The following is a description of a gene set: from publication Barrier A, Lemoine A, Boelle PY, Tse C, Brault D, Chiappini F, Breittschneider J, Lacaine F, Houry S, Huguier M, Van der Laan MJ, Speed T, Debuire B, Flahault A, Dudoit S (PMID 16091735) Human Gene Set: BARRIER_CANCER_RELAPSE_NORMAL_SAMPLE_DN studied in species Homo sapiens Down-regulated genes in non-neoplastic mucosa samples from colon cancer patients who developed recurrence of the disease. This study assessed the possibility to build a prognosis predictor, based on microarray gene expression measures, in stage II and III colon cancer patients. Tumour (T) and non-neoplastic mucosa (NM) mRNA samples from 18 patients (nine with a recurrence, nine with no recurrence) were profiled using the Affymetrix HGU133A GeneChip. The k-nearest neighbour method was used for prognosis prediction using T and NM gene expression measures. Six-fold cross-validation was applied to select the number of neighbours and the number of informative genes to include in the predictors. Based on this information, one T-based and one NM-based predictor were proposed and their accuracies were estimated by double cross-validation. In six-fold cross-validation, the lowest numbers of informative genes giving the lowest numbers of false predictions (two out of 18) were 30 and 70 with the T and NM gene expression measures, respectively. A 30-gene T-based predictor and a 70-gene NM-based predictor were then built, with estimated accuracies of 78 and 83%, respectively. This study suggests that one can build an accurate prognosis predictor for stage II and III colon cancer patients, based on gene expression measures, and one can use either tumour or non-neoplastic mucosa for this purpose., and this is the list of marker genes: AKAP17A, INTS1, HSPA1A, ZFP36L1, TCIRG1, VPS37C, NSMF, JUN, CPSF1, NPIPB3, PPP1R15A, PSD4, SPG7, SUPT5H, N4BP2L2, FAAP100, NFE2L1, TLE6, GNB1L, TBC1D2B, SPTAN1, CNPY3, TYK2, LAMP1, RHOT2, ALG13, CSNK1G2, ATG4B, STK25, CDK10